The following is a description of a gene set: The process whose specific outcome is the progression of the nose over time, from its formation to the mature structure. The nose is the specialized structure of the face that serves as the organ of the sense of smell and as part of the respiratory system. Includes the nasi externus (external nose) and cavitas nasi (nasal cavity). species: Mus musculus Mouse Gene Set: GOBP_NOSE_DEVELOPMENT, and this is the list of marker genes: Sox2, Stra6, Gng8, Aldh1a3, Ascl1, Six4, Msx1, Rpgrip1l, Pou2f1, Six1, Chd7 (chromodomain helicase DNA binding protein 7), Dlx5, Rdh10, Hesx1, Smchd1 (SMC hinge domain containing 1), Ski (ski sarcoma viral oncogene homolog (avian))